The following is a description of a gene set: Neighborhood of FBL fibrillarin in the MORF expression compendium species: Homo sapiens Neighborhood of FBL Human Gene Set: MORF_FBL, and this is the list of marker genes: MRPL9, RAD23A (RAD23 homolog A, nucleotide excision repair protein), KXD1, NAP1L1, HNRNPAB, SNRPA, NUDT1, EIF3C, FBL, BANF1, TBL3, SNRPD2, ATP5F1D, TMEM147, RBBP4, CCT2, SET, GPI, DRG1, BTF3, TUFM, HNRNPA2B1, BUB3, H2AZ1, MCM2, EIF3K, ATP5F1A, HSP90AB1, EEF1E1, HDGF, PSMB2, EIF4H, XRCC6 (NCBI Gene Id 94359), CCT7, EIF3E, LSM7, HNRNPUL1, SNRPA1, CYCS, VDAC2, KARS1, HNRNPA3P1, RBMX (RNA binding motif protein X-linked), RSL1D1, TARDBP, HPRT1, SNRPB, UBE2L3, NDUFV1, SF3A2, UQCRFS1, RUVBL2, JTB (jumping translocation breakpoint), ATP5PO, MCM7, EIF4B, PUF60, SERBP1, CSNK2B, UQCRH, HSP90AA1, ATP5MC3, DEK, NME1, FUS, DDX49, IDH3B, LSM2, UBA2, AHCY, SRSF3, UBE2I, PSMB7, HNRNPA1, U2AF1, RPL10A (ribosomal protein L10a), CS, PDAP1, HNRNPC, YWHAQ, PPP2R1A, SRSF9, YBX1, SUMO2 (NCBI Gene Id 6613), NCL, PHB2, CYC1, TOMM20, DOCK3, CDC123, ANAPC5, PCNA, ATP5MC1, RAN, EIF3G, PSMD8, PPM1G, RALY, SNRPE, PRMT1, TAF11, POLR2I, CCT3, SOD1 (NCBI Gene Id 6647), RPL6, CBX3, SLC25A3, CLNS1A, COA1, POLE3, DDOST, KHDRBS1, IMPDH2, RPL14, HSPD1, PARK7, ILF3, STARD7, SUMO3, HCCS, ATXN10, FIBP, HMGN1, LYPLA1, EIF4A1, NDUFS3, NONO, AURKB, C1QBP (NCBI Gene Id 708), EIF3I, FAU, PTGES3, SSBP1, EIF3B, ANP32B, PSMB1, ILF2, RNPS1, TRIM28, LSM4